Given this list of marker genes IL1B, MSR1, APOE, RGS10, LAPTM5, LY86, CSF2RA, ITGB2, HLA-DQA1, MNDA, GPR183, RAB32, YWHAH, P2RY13, RGS1, RGS2, ZNF331, HLA-DQB1, COTL1, FCGR2A, HLA-DMB (major histocompatibility complex, class II, DM beta), HLA-DPA1 (NCBI Gene Id 7935), CSF1R, CLEC10A, HLA-DMA, FCGR3A, LST1, TYROBP, SRGN, CCL4L2, RNASET2, CEBPD, CXCR4, TREM2, CCL3, C1QC, PLD4, C3, FCER1A, HLA-DRB1, SPI1, APOC1, MS4A6A, C1QA, IGSF6 (NCBI Gene Id 10261), CD74, HLA-DRB5, MS4A7, HLA-DQA2, FCER1G, CST3, PLAUR, CLEC7A, CD68 (CD68 molecule), HLA-DPB1, FTL, CXCL16, IFI30, GPR34, CYBA, FGL2, C15orf48, SGK1, TYMP, AIF1, RNASE6, CD14, C1QB, NR4A2, CX3CR1, C3AR1, CTSS, CD83, HLA-DRA (major histocompatibility complex, class II, DR alpha), SLC40A1, HERPUD1, NPC2, PHACTR1, DUSP1, GRN, here is a description of the gene set: Human Gene Set: DURANTE_ADULT_OLFACTORY_NEUROEPITHELIUM_MACROPHAGES studied in species Homo sapiens from publication Durante MA, Kurtenbach S, Sargi ZB, Harbour JW, Choi R, Kurtenbach S, Goss GM, Matsunami H, Goldstein BJ (PMID 32066986)